Given this list of marker genes SLC25A19, SLC19A2, THTPA, TPK1, SLC19A3, here is a description of the gene set: Human Gene Set: REACTOME_VITAMIN_B1_THIAMIN_METABOLISM Vitamin B1 (thiamin) metabolism species: Homo sapiens